Given this list of marker genes GNAT1 (G protein subunit alpha transducin 1), CFH, LTB, CST6, KIAA1549L, NEAT1, LGALS3BP, GALNT3, FGFR3, CRYBB1 (NCBI Gene Id 1414), TSPY1, TSPAN7, DUSP2, FBLN2, EDNRB, AREG, DSC3, IFI27, MAL, CCND1, CCN2, IFIT3, AZGP1, MS4A1, here is a description of the gene set: from publication Zhan F, Hardin J, Kordsmeier B, Bumm K, Zheng M, Tian E, Sanderson R, Yang Y, Wilson C, Zangari M, Anaissie E, Morris C, Muwalla F, van Rhee F, Fassas A, Crowley J, Tricot G, Barlogie B, Shaughnessy J Jr (PMID 11861292) studied in species Homo sapiens 'Spiked' genes: genes most highly up-regulated in multiple myeloma samples; were not differentially expressed as compared to the normal plasma cells. Bone marrow plasma cells (PCs) from 74 patients with newly diagnosed multiple myeloma (MM), 5 with monoclonal gammopathy of undetermined significance (MGUS), and 31 healthy volunteers (normal PCs) were purified by CD138(+) selection. Gene expression of purified PCs and 7 MM cell lines were profiled using high-density oligonucleotide microarrays interrogating about genes. On hierarchical clustering analysis, normal and MM PCs were differentiated and 4 distinct subgroups of MM (MM1, MM2, MM3, and MM4) were identified. The expression pattern of MM1 was similar to normal PCs and MGUS, whereas MM4 was similar to MM cell lines. Clinical parameters linked to poor prognosis, abnormal karyotype (P =.002) and high serum beta(2)-microglobulin levels (P =.0005), were most prevalent in MM4. Also, genes involved in DNA metabolism and cell cycle control were overexpressed in a comparison of MM1 and MM4. In addition, using chi(2) and Wilcoxon rank sum tests, 120 novel candidate disease genes were identified that discriminate normal and malignant PCs (P <.0001); many are involved in adhesion, apoptosis, cell cycle, drug resistance, growth arrest, oncogenesis, signaling, and transcription. A total of genes, including FGFR3 and CCND1, exhibited highly elevated (spiked) expression in at least 4 of the 74 MM cases (range, 4-25 spikes). Elevated expression of these genes was caused by the translocation t(4;14)(p16;q32) or t(11;14)(q13;q32). Thus, novel candidate MM disease genes have been identified using gene expression profiling and this profiling has led to the development of a gene-based classification system for MM. Human Gene Set: ZHAN_MULTIPLE_MYELOMA_SPIKED